The following is a description of a gene set: studied in species Homo sapiens Reactome Pathway: Metabolism of steroids Steroids, defined by a four-ring cyclopentaphenanthrene carbon skeleton, include cholesterol and bile acids and salts, steroid hormones, and vitamin D, three groups of molecules synthesized from it. In this module, pathways for the synthesis of cholesterol from HMG-CoA (hydroxymethylglutaryl-coenzyme A), and for its conversion to bile acids and salts, steroid hormones (Payne & Hales 2004), and vitamin D are annotated, together with the SREBP-mediated regulatory process that normally links the rate of cholesterol synthesis to levels of cellular cholesterol (Brown & Goldstein 2009). part of: Metabolism of lipids, and this is the list of marker genes: TSPO, HSD17B11 (NCBI Gene Id 51170), MED1 (mediator complex subunit 1), AKR1B1, POMC, FDX2, AKR1C2, CYP27A1, NSDHL, TM7SF2, ABCC3, MVK, OSBPL1A, CYP46A1, MVD, GGPS1, SC5D, BAAT, GC, CYP2R1, NFYB, ACAT2, OSBPL6, SQLE, HSD17B12, HSD3B1, CARM1 (coactivator associated arginine methyltransferase 1), SEC24D (NCBI Gene Id 9871), AKR1C1, ACACB, CYP51A1, HELZ2, NFYC, STARD3, HSD17B4, OSBPL3, AKR1D1, CGA (NCBI Gene Id 1081), SREBF2, PMVK, AMACR, HSD3B2, GPAM, TBL1X, SCP2, FABP6, UBE2I, OSBPL7, CHD9, OSBP (NCBI Gene Id 5007), DHCR24, SP1, TGS1, SEC24A, LGMN, STS, RXRA, SLCO1B3, SEC24C, NCOA6, STARD4, LBR, CYP7B1, NCOA1, KPNB1, AKR1B15, HMGCS1, SCD, CYP39A1, MTF1, NFYA, ALB, CUBN, CYP27B1, LRP2, LDLRAP1, TSPOAP1, SLC10A1, SRD5A1, NCOA2, CH25H, SLC27A5, SLC27A2, FDFT1, ACOT8, ABCB11, ACACA, CYP11B2, CYP7A1, CYP21A2, EBP, SCAP, IDI2, SUMO2, CYP8B1, FDX1, PLPP6, NR1H4, INSIG1, SMARCD3, LHB, CYP11A1, PPARA, FASN, FDXR, CREBBP, CYP17A1, STARD3NL, ARV1, IDI1, SLC51A, CYP19A1, SEC23A, HSD11B2, TBL1XR1, SLC51B, RAN, STAR, HSD17B1, SAR1B, SRD5A3, MBTPS1, HSD3B7, HSD11B1, LSS, SLCO1A2, MSMO1, CYP11B1, SLC10A2, VDR, CYP24A1, SERPINA6, MBTPS2, DHCR7, AKR1C4, HSD17B2, ACOX2, SRD5A2, SLCO1B1, HSD17B7, STARD6, HSD17B14, STARD5, INSIG2, AKR1C3, SEC24B, HMGCR, FDPS, OSBPL2, HSD17B3, OSBPL9, SREBF1, PIAS4, ELOVL6